Given this list of marker genes DBT, PUF60, RANBP2, LSG1, MATR3, PENK, FOXN3, PSMD14, LPXN, GPR84, RABEPK, IPO7, HMGN3, TMEM41B, PDCD5, MIR202, GCN1, SPATA7, ESD, CIAO2A, TBR1, PLXND1, TUBGCP2, TNFAIP8L1, RPS4Y2, NR1D2, SPIN1, BCCIP, MRPL2, YRDC, MAST2, RAB10, TRIM62, TPD52L2 (NCBI Gene Id 7165), COPS8, RILPL1, SEPHS2, SNU13, MIR491, HAUS1, LARP1, TARBP2, HRAS (NCBI Gene Id 338029), UROS, VPS29, BOP1, TBL3, RFC3 (NCBI Gene Id 5983), PFKL, ZBED3, HPDL, FAM83H, ARL8B, ST18, ABHD6, TULP3, CACNB3, POLE4, METTL6, POP1, TRAFD1, MN1, MRPL52, SLC1A2, MED21, GRM6, SPRYD4, TRIM37, CYC1, NUS1, MNAT1, ATP1A1, NCS1, GTSE1, SRSF1, NLGN2, BTF3L4, CENPB, SAR1A, SWAP70, TMEM120B, DDX60, SLC35F2, RESP18, CEP41, LEO1, FAIM, DCBLD1, RPS2, JAGN1, HAT1, DVL1, ECD, TRMT61A, MX1, NDUFS8, GCSH, THOC5, CCR7, WDR26, LRRC8D (NCBI Gene Id 55144), TNFAIP1, SNRPD1, AAMP, OSGEP, GFPT1, TRMT10A, UMPS (uridine monophosphate synthetase), PSMD4, CNIH2, SMAD6, MXRA8, UQCRC1, CHMP1A, CCDC87, CCDC8, PRKCI, POLR3B, P3H1, JTB, MRPL3, SCAP, ZC3HC1, EHD1, ZFPM1, REM2, PDXP, PLK3, SSPN, MRPL16, PDCL3, YBX3, RSAD1, POLR1G (RNA polymerase I subunit G), FAM118A, SMU1, IRF4, TBC1D15, F3 (coagulation factor III), PSME1, TPSAB1, CSF1, KARS1, PTPDC1, SNORD38A, HEYL, IL1A, TTBK2, SPCS1, RNF157, CTU2, PSMA5, TMEM11, ALG8, TUBB6, MSRB3, IGF2BP3, NQO1, SCO1, SPAM1, PRPF40B, NAF1, NUP43, EIPR1, REL, SYTL3, MED9 (NCBI Gene Id 55090), APIP, MESD, SF3B5, here is a description of the gene set: The transcription factor FoxP3 partakes dominantly in the specification and function of FoxP3+ CD4+ T regulatory cells (Tregs), but is neither strictly necessary nor sufficient to determine the characteristic Treg transcriptional signature. Computational network inference and experimental testing assessed the contribution of several other transcription factors (TFs). Enforced expression of Helios or Xbp1 elicited specific signatures, but Eos, Irf4, Satb1, Lef1 and Gata1 elicited exactly the same outcome, synergizing with FoxP3 to activate most of the Treg signature, including key TFs, and enhancing FoxP3 occupancy at its genomic targets. Conversely, the Treg signature was robust to inactivation of any single cofactor. A redundant genetic switch thus locks-in the Treg phenotype, a model which accounts for several aspects of Treg physiology, differentiation and stability. species: Homo sapiens Human Gene Set: GSE40274_CTRL_VS_LEF1_TRANSDUCED_ACTIVATED_CD4_TCELL_DN Genes down-regulated in CD4 T conv: control versus over-expression of LEF1. from publication Fu W, Ergun A, Lu T, Hill JA, Haxhinasto S, Fassett MS, Gazit R, Adoro S, Glimcher L, Chan S, Kastner P, Rossi D, Collins JJ, Mathis D, Benoist C (PMID 22961053)